The following is a description of a gene set: studied in species Homo sapiens Human Gene Set: GOBP_NEGATIVE_REGULATION_OF_INTERLEUKIN_1_PRODUCTION Any process that stops, prevents, or reduces the frequency, rate, or extent of interleukin-1 production., and this is the list of marker genes: GAS6, MIR766, MIR98, IL10, HDAC3, CARD8, APOA1, MIR27B, FFAR1 (free fatty acid receptor 1), MIR142, CEACAM1, FFAR4, ARRB2, NLRP12, NLRP7, GSTP1, MIR101-1 (microRNA 101-1), MIR920, NLRP2B, TREM2, MIR181D, MEFV, GHSR, TNFAIP3, PYDC2, MIR877, ACP5, CARD16, GHRL, MIR708, CARD18, MIR181A2, RAD21, CPTP, CX3CL1, CX3CR1, MIR181C, MIR204, CARD17P, IL1R2, IGF1, ERRFI1, MIR132, MIR488, ELF4, SERPINB1, ZC3H12A, MIR195, NLRP3, CD33, NR1H4, GIT1, PYDC1, LILRB4, PML